Given this list of marker genes CHD4, CEP120, SLC26A2, XYLT1, COMP, COL2A1, MATN3, LYSET, TRIP11, CSGALNACT1, WDR35, INPPL1, PTH1R (NCBI Gene Id 5745), RAB33B (NCBI Gene Id 83452), TRPV4, IFT52, FLNB, COG1, GNPNAT1, FIG4, PAM16, GNPTAB, SLC35D1, FGFR3, GPX4, DYM, BGN, CANT1, NANS, CCN2, here is a description of the gene set: Flat acetabular roof Human Gene Set: HP_FLAT_ACETABULAR_ROOF Flattening of the superior part of the acetabulum, which is a cup-shaped cavity at the base of the hipbone into which the ball-shaped head of the femur fits. The acetabular roof thereby appears horizontal rather than arched, as it normally does. studied in species Homo sapiens